The following is a description of a gene set: Reactome Pathway: Formation of Senescence-Associated Heterochromatin Foci (SAHF) part of: DNA Damage/Telomere Stress Induced Senescence This event has been computationally inferred from an event that has been demonstrated in another species.<p>The inference is based on the homology mapping from PANTHER. Briefly, reactions for which all involved PhysicalEntities (in input, output and catalyst) have a mapped orthologue/paralogue (for complexes at least 75% of components must have a mapping) are inferred to the other species. electronically inferred by orthology from the curated human pathway species: Mus musculus, and this is the list of marker genes: Rb1, H1f1, Lmnb1, H1f4, H1f5, Hmga1, Trp53, H1f3, Ep400